The following is a description of a gene set: Genes predicted to be targets of miRBase v22 microRNA hsa-miR-944 in miRDB v6.0 with MirTarget v4 prediction scores > 80 (high confidence targets). studied in species Homo sapiens from publication Chen Y, Wang X (PMID 31504780) Human Gene Set: MIR944, and this is the list of marker genes: CFAP97, TSPAN13, DCLK1, FAM8A1, RFTN2, ODAPH, COBLL1, TAF5L, RTKN2, FSD1L, NEUROD1, GBP1, BICC1, ERICH3, ZBTB1, TEP1, PGBD1, C2, COG6, ARID1B, IYD, GLRA2, PGAP1, PDCL, GABPB1, CAMK4, TMEM68, EFHC2, NDUFAF3, CBLB, CRBN (cereblon), TMEM64, TRAFD1, GTF2A1, HOXB2, SGIP1, ERG, HRH4, NHEJ1, SPOP, MCTP2, PRRX1, PTBP3, AVPR1A, RORA, CHRNA5, WAPL, ZMYM6, PRKCH, CROT, DPP8, ZNF107, CACNB4, ACSL4, CCDC15, NSUN3, ZBTB41, C5orf24, SPAG16, ACTR1B (actin related protein 1B), PRDM1, KAT2B, WEE1, SLC2A11, ZNF655, B3GNT5, BDNF, TMED7, EBAG9, GPR155, CREB5, PPP1R1C, QKI, GLYATL1, CREB1, CLOCK, ULBP1, BHLHE40, MS4A1, TRAF3, HOXC8, USP32, MACC1, EPC2, ANTXR2, METTL15, U2SURP, SGPP1, PPP3CA, MRPS5, TFEC, GBP3, PANK2, DLC1, GLYAT, PTPN4, HCN1, LPIN1, CMPK2, CCDC178, ABHD16A, OTOA, TMEM167A, ZNF83, POU2AF3, HPGD, TMEM236, STRIP2, ZNF264, MMS22L, BHLHE41, BPNT2 (NCBI Gene Id 54928), SNTB2, TMEM59, ATP6V1G2, MYBL1, GMPPB, IGFBP3, TSNAX, ST8SIA4, SLC4A7, GUF1, BLTP1, RHAG, PRDM10, OGN, SBSPON, CLINT1, SEMA3D, PRKACB, TRMT13, IKZF2, GXYLT1, PDZD2, GNRHR, RASD1, GPATCH2L, ELMOD2, KCNT2, PIAS2, FGL2, CLVS2, ANKRD20A2P, TRIM5, TRPS1, LARP4, TMEM65, FZD3, ZNRF2, TCHHL1, CERS6, FGF2, SYT14, STEAP2, RAPGEF2, DCC, IRS2, ZCWPW2, SLC2A13, MGA, MAP3K2, MNAT1, IL5RA, RBM46, ARL13B, PAFAH1B2, NPAS3, LPIN2, SEMA3C, KLF12, ANKRD20A1, PEG10, FBN1, SRRM4, ZNF451, GPATCH2, ZPLD1, LEPROTL1 (NCBI Gene Id 23484), FHL5, SEPSECS (Sep (O-phosphoserine) tRNA:Sec (selenocysteine) tRNA synthase), MANEA, NR2F1, GJB2, PAM, DOCK5, NUDT12, INO80D, GLO1, GRIA4, ZNF439 (zinc finger protein 439), LOX, SLC49A4, RASSF6, INPP5A (NCBI Gene Id 3632), PIK3C2A, KATNBL1, BCO2, PTP4A1, ZNF684, ECHDC1, GFM1, PHLPP2 (PH domain and leucine rich repeat protein phosphatase 2), FUT9, C2orf69, TNFAIP2, POLR3G, ANKRD20A3P, RASEF, SLC35A5, TMX3, ETFRF1, VSTM4, PHEX, TRDN, PRRG3, DGKH, JCHAIN, CFAP418, HS3ST3B1, HOXB5, SLC4A5, ZDHHC17, PAN3, PTPRC, TMEM106B, TCFL5, PCGF5, SAP30, CHD9 (chromodomain helicase DNA binding protein 9), MEX3A, TIAM2, GRIK1, BRAF, SPIN1 (spindlin 1), KIAA1549, BRWD3, HOOK3, GRM7, STXBP1, TMEM47, COX11, ATP11C (NCBI Gene Id 57206), RTN1, FSHR, COL19A1, TOMM70, AHCTF1, ZC3H12B, DCDC2, DLGAP1, PRKG1, MMP16, SPAST, TMEM237, RECK, DDX31, HNMT, MAP7, COA8, GABRB2, PTPRB, CNPY1, WASHC4 (NCBI Gene Id 23325), POF1B, ARPIN, HTR1F, PNRC1, CUBN, FNDC3B, CPEB2, ZC3H6, RALGPS2, H3-3A (NCBI Gene Id 3020), USF3, UBL3, KLHL23, GNB5, KIF5B, TINF2, EXT1, IFT57, PIK3CA, NEDD1, RAB33B, DNAAF6, PHTF2, CYBRD1 (cytochrome b reductase 1), ZBBX (zinc finger B-box domain containing), ZDBF2, C11orf71, SP5 (Sp5 transcription factor), RBMS3, TERB2, NDUFS1, PAK2, RAD23B, ZNF326, SNX18, ABCA6, RGS14, LRCH2, PLPPR5, GCLM, TEKTL1, ITFG1, VPS13C, DENND1B, CCDC148, DICER1, PPM1E, PIK3CG, TSC22D4, TC2N, NUP153, BLTP3B, JRKL, VAMP4, NF1, PLA2G12A, MPC1, NKD1, SCD, SOCS4, AASS, MED17, TMEM26, NOVA1, PHC3, FAM135A, MCMBP, TBCEL (NCBI Gene Id 219899), TSC22D2, ESR2, GPSM1 (G protein signaling modulator 1), TBC1D12, TMPRSS11E, CADM2, IFT56, THOC3, MIX23, LUZP2, GLCE, COLEC12, LATS1, SORBS2, SPATA6, PDLIM5, BCL11B, SREK1IP1, ADAM10, NCOA2, SULT6B1, DPP9, FAM199X, SEC24D, TSHZ1, ANKRD20A4P, TMEM182, ELK4, SSPN, LRRTM2, ZNF737, ABCB11, SLC41A2, ESRRG, MAGEF1 (NCBI Gene Id 64110), NFS1, MIER3, SASH1, CISH, AKIRIN1, PPARGC1A, CLCN3, ARSK, CUL2 (NCBI Gene Id 8453), STAM2, TMEM135, FAM76B, MMP10, MYEF2, MPP7 (NCBI Gene Id 143098), CASK, F2RL1, BRCA1, ODC1, CA1, XPO4, NPEPPS (NCBI Gene Id 9520), ERBIN, THEMIS, LRAT, CHIC1, ONECUT2, PABPC5, PDSS2, ZMYM2, GPC6, WWP2, PMS1, AP1S3, APPL1, DCBLD2, EIF3J, ACTR3, TREM1, PGM3, SLC35A3, SGCB, PCLO, TAF4B, RERE, KCNH2, FAM174A, RELCH, PDE10A, MYSM1, FANCC, SPOCK3, PCBD2, OGFRL1, POU1F1, SMS, OTULIN, ETS2, RFX4